Given this list of marker genes TUBAL3, TUBB4B, RPS27A, TUBA4A, UBE2N, DYNC1LI2, TUBB2A, ARL13B, DYNC1I1, TUBB6, TUBA1B, CFTR, UBE2V1, TUBB1, TUBA4B, HSF1, DYNLL2, VCP, IFT88, TUBB3, PRKN, VIM, TUBB8, TUBA3C, DYNC1H1, CETN1, UBB, PARK7, TUBA3D, TUBA8, UBC, PCNT, TUBB4A, TUBB8B (NCBI Gene Id 260334), HDAC6, DYNC1LI1, TUBB2B, HSP90AA1, TUBA1A, TUBA1C, DYNLL1, TUBA3E, DYNC1I2, UBA52, here is a description of the gene set: studied in species Homo sapiens When the capacity of the proteosome to degrade misfolded proteins is limited, the alternate route to eliminate denatured proteins is via forming aggresomes - a process known as aggrephagy. Aggresome formation starts with ubiquitination of misfolded proteins following transport to the microtubule-organizing center (MTOC) with the help of dynein motor proteins. At the MTOC the cargo is encapsulated with intermediate filament proteins to result in the aggresome. Subsequently, this aggresome recruits chaperones that result in its autophagic elimination (Garcia Mata R et al. 2002). part of: Selective autophagy Reactome Pathway: Aggrephagy